Given this list of marker genes GJB1, ATXN1, ATXN3, MAN2B1, ATXN2, PLP1, TDP1, PRKAR1B, GCLC, REPS1, here is a description of the gene set: species: Homo sapiens Spinocerebellar tract degeneration Human Gene Set: HP_SPINOCEREBELLAR_TRACT_DEGENERATION